The following is a description of a gene set: studied in species Homo sapiens Genes down-regulated in CD4 T conv: control versus over-expression of GATA1. The transcription factor FoxP3 partakes dominantly in the specification and function of FoxP3+ CD4+ T regulatory cells (Tregs), but is neither strictly necessary nor sufficient to determine the characteristic Treg transcriptional signature. Computational network inference and experimental testing assessed the contribution of several other transcription factors (TFs). Enforced expression of Helios or Xbp1 elicited specific signatures, but Eos, Irf4, Satb1, Lef1 and Gata1 elicited exactly the same outcome, synergizing with FoxP3 to activate most of the Treg signature, including key TFs, and enhancing FoxP3 occupancy at its genomic targets. Conversely, the Treg signature was robust to inactivation of any single cofactor. A redundant genetic switch thus locks-in the Treg phenotype, a model which accounts for several aspects of Treg physiology, differentiation and stability. from publication Fu W, Ergun A, Lu T, Hill JA, Haxhinasto S, Fassett MS, Gazit R, Adoro S, Glimcher L, Chan S, Kastner P, Rossi D, Collins JJ, Mathis D, Benoist C (PMID 22961053) Human Gene Set: GSE40274_CTRL_VS_GATA1_TRANSDUCED_ACTIVATED_CD4_TCELL_DN, and this is the list of marker genes: ATMIN, DENND2C, CSTB, KLF6, CNOT6L, MANEA, PUF60, KIF18A, TPST2, XPNPEP3, ATF4, SIAH2, IGF2R, RBM8A, VPS18, BAMBI, EIF4A3, CAMK2N2, HSPA4L, POMC, CFAP46, APTX, ELL2, PRELID3B, NRBP1, FAM76A, SUCO, CCDC117, MXD1, HIC2, MOB2, MIRLET7D, GTF2H5, RCL1 (NCBI Gene Id 94533), SCGB2A2, MEX3C, RHEB, RBM7, CAMSAP2, C6orf62, KLHDC4, MED7, SCPEP1, PCDHB18P, NMT2, PEG10, STK38L, IER3, USP22, ART5, TRIB1, BCL2L11, TMPRSS3, PHF19, ARIH2, CSRP1, DPH3, FIGN, ZCCHC12, ITK, UBQLN1 (ubiquilin 1), TNFRSF10B, ORAI1, EIF6, USP31, HYCC1 (NCBI Gene Id 84668), COQ8A, ARID5A, PRRG4, CDKN2B, SDE2, UBE2S, CCSAP, FGFRL1, EGR4, GTF2E2, ZC3H10, CCNL1, H1-10, IL21R, VEGFA (vascular endothelial growth factor A), MIR17HG, MIR16-1, BACH1, H1-2, DEGS1, SLC16A6, HSP90AB1, EIF1AX, NUP54, MAFG, SLAMF9, SESN2, TAF13, RELB, PLK4, CLEC4E, UNC45A, PTP4A1, CRYGN, RTN4RL2, BHLHE41 (basic helix-loop-helix family member e41), KLHL11, MAFK, PPP1R12B, DNAJA2, IL3RA, C15orf39, SNORA20, NXF2, PLCXD2, GHITM, TOB2, PIP5KL1, CDV3, CAPN11, DDX54, SNRPA, LYSET, CXCL2, NFATC1, DGKD, S1PR2, MIR103A1, CABYR, CD93, MIR7-1, SLC18A3, EIF3A, TRIB2, USP44, CYLC1, PMF1, HSPB1, RASSF3, EZR, UQCRFS1, ZBTB25, IWS1, ZSCAN10, MAGOH, GCH1, ZRSR2, CAMK2N1, LINC-PINT, PLK3, ZC3H12A (NCBI Gene Id 80149), FMO4, NFKBIB, TOX3, CLRN2, IRF2BP2, RASAL1, MAP3K1, DTWD2, DMRTB1, SH3TC1, BSPRY, TOP1, CBX4, ARRDC3, STAP1, PIK3IP1, DCAF12L1, ERF, KPNA4, PNPO, ADORA2A, TMEM167B, MIR24-2, BCL2L13, PHLDA1